Given this list of marker genes PRAMEF11 (PRAME family member 11), FHIT, UBA6, CAV3 (caveolin 3), RPL5, DERL1, STYX, WDR26, USP17L6P, FEM1C (NCBI Gene Id 84463), TRIB1, SHARPIN, RNF6, SIRT2, COP1, PTK2, SUMO1, RNF133, PSMD4, CSNK1D (casein kinase 1 delta), PCNP, HSPA1B, RBBP6, RNF5, CAMLG, KLHL23, RNF126 (NCBI Gene Id 55658), SMURF1, ZER1, SPSB1, USP33, FBXL2, MIB1 (MIB E3 ubiquitin protein ligase 1), SIAH3, LTN1, DCST1, FBXL5, TRIM2, HUWE1, TRIM72, PSMD9, ARK2N, CHMP4C, SPSB3 (NCBI Gene Id 90864), LIAT1, RBCK1, RNF20, ANAPC5, UBXN2A, TP53INP2 (NCBI Gene Id 58476), FBXL13, MDM2, FBXO48, RNF19B, RNF25, FBXL4, KLHL5, HERC5, TENT4A, PANO1, PABPN1L, PSMC6, FBXO39, PRAMEF6, TRIM31, UBQLN2, MAEA, SMAD7, PSMB10, KLHDC1, ADRM1, UBE2G1, AMBRA1, TMEM168, UBXN1, FBXL15, PRAMEF10, KLHL29, GID8, UBE3C, PRAMEF14, AURKA, APC, RNF186, LONP1, RNF7, PRAMEF33, DCAF11, KCTD10, RNF166, AGTPBP1, ASB2, TRIM32, KLF1, USP5, ECRG4, HERC6, HSPA1A, UBE2R2, MAPK9, STAM, ARRB2, SH3RF1, FAF1, KLHDC3, TRPC4AP (NCBI Gene Id 26133), VPS28, DVL1, UBE3B (ubiquitin protein ligase E3B), KLHL25, RNF19A, UBE2Z, SQSTM1, UBR4, SNF8 (SNF8 subunit of ESCRT-II), ASB1, FBXL19, UFD1, CDK5RAP3, CDC20B, FOXF2, CHMP1A, MKRN2, FBXW8, KLHL8, DCAF1, SKP1, GET4, UBE2D4, USP9X (ubiquitin specific peptidase 9 X-linked), PSMB7, ANAPC2, FBXO11, TNFAIP3, KLHL3, TRIP4, SPSB2, PJA2, KCTD2, HECTD1, UBE2H (NCBI Gene Id 7328), TRIM39, DNAJB2, RNF4, UBE2D2, PCYOX1, HERC3, CHMP2B, FBXL7, ATXN3L, TGFB1I1, FBXL3, KBTBD3, UBQLN1, SMARCC1, PSMD2, CUL4A, CHFR, PIAS1, PSMA5, NCCRP1, PRAMEF5, RNF144A, SIAH1, KLHL12, RNF8, GSK3A, VPS37A, RNF34 (NCBI Gene Id 96268), CHMP1B, PSMC3, IFI27, GIPC1, PSMC2, CLU, PSMC5, RNF167, PRAMEF27, UBXN2B, NHLRC1, KLHL30, HAMP, ARRB1, ANAPC15, CHMP7, WWP1, DDRGK1, COPS3, TRIM45, NHLRC3, AKT1, RNF150, PEX12, MTM1, PSMD13, PAQR3, TBL1X, PSMB4, UBE2N, USP38, CHMP4A, PRAMEF13, STUB1, PABIR1, AREL1, UBC, CUL4B, SPSB4, ITCH, CDC20, FAU, IPP, UCHL5, CHMP5, RNF130, HECW1, ZSWIM8 (NCBI Gene Id 23053), UBA7, PSMD11, FBXO38, RNF185, CUL5, BTRC, TRIM58, UBE2L3, PSMD1, KLHL20, CDC23, UBD, DDA1, STAM2, PRKN, RNF144B, UFL1, USP44, USP28, RNF115, RHOBTB3, UBE3D, CDK2, CSNK2A1, PRAMEF25, RNF170, CNOT4, RAD23A, COMMD1, PRAMEF26, UBE2E1, ARMC8, PSMD12, PSMB2, SH3RF2, RMND5A, LRRK2, PEX10, UBA1, KBTBD8, XPO1, SIAH2, KLHL24, NTAN1, PRAMEF4, PELI1, WWTR1, KLHL11, RNF43, CDKN2A, SIRT6, FBXO2, MYLIP, ZFAND2B, PLK1, FBXW4, KCTD13, UBE2S, AXIN2, CSNK2A2, PSMB3, CHMP6, SOCS5, SEM1, NAGLU (N-acetyl-alpha-glucosaminidase), SPOP, PSMB6 (NCBI Gene Id 95505), PARK7, SOCS7, TRIM9, CCDC22, FBXO3, WNT10B, NKD2, UBE3A, SHH, VPS37D, AXIN1, PCYOX1L, CUL3 (NCBI Gene Id 8452), ARMC5, CDC16, TRIP12, PPP2CB, RNF128, TRIM38, ANAPC10, KLHL1, DTL, PRAMEF2, APC2, KLHL28, MAP1A, UBQLN3, SENP1, KLHL40, RPS7, FBXW11, LATS1, FBXO45, HACE1, FBXO4, RNF125, UBQLNL, DIS3L2, APPBP2, NEDD4, ASB11 (NCBI Gene Id 140456), ERCC8, KLHL7 (kelch like family member 7), DESI1, PRAMEF20, USP17L24, VHL, CBLC, GSK3B, UBAP1L, TOLLIP, WDR81, PRAMEF1, BAG5, RNF145, FBXO21 (F-box protein 21), GBA1 (glucosylceramidase beta 1), PSMA2, PDCL3, VPS4A, IL33, USP14, RNF217, DDIT3, FBXL17 (F-box and leucine rich repeat protein 17), PBK, MARCHF6, ASB9, ANKIB1, KLHL21, PSMF1, TRAF4, NPLOC4, RPL23, USP7, VPS25, CSNK1A1, HERPUD1, RNF149, PSMD8, TF, KEAP1, RNF13, KAT5, DTX4, TRIM25, EDEM1, ZMPSTE24, RNF10, GCLC, CCAR2, PRAMEF9, RC3H1, SIRT1, PHF20L1, FBXO6, VPS4B, KCTD21, KBTBD2, OGT, AMFR, OTUD7B, PRAME, CHMP4BP1, UBB, AGBL4, ATXN3, UBXN11, KLHL4, KLHL17, RPL11, TSG101, TRIM3, PSMD6, FZR1, KIF14, PSMA8, RNF215, PPP2R5C, MTA1, NUB1, CUL9, ISG15, AGAP3, DISC1, NFE2L2, BFAR, FBXL16, ATE1, RC3H2, RBX1 (NCBI Gene Id 9978), UBE2D3, CCNF, HECTD3, FBXL14, PSMA4, SMURF2, HERC2, ARAF, PRAMEF22, PSMC1, CDC27, UBE2W, NEDD4L, DCAF12, CRBN, EPG5, CBL, PRAMEF12, PSMD14 (proteasome 26S subunit, non-ATPase 14), UBE2J2, ANAPC1, RAD23B, PSMD7, RNF122, GID4, ARHGAP5-AS1, PYHIN1, PSMD10, ZYG11B, UBR5, FBXW7, UBR1, UBR3, KLHL35, PSMB11, PRMT6, DTX3L, NEMF, UBE2K, CACUL1, BIRC2, VPS36, TTC3, SKP2, VPS37B, UBE4A, LAPTM5, ANAPC11, ASCC2, PLK3, ARIH2, N4BP1 (NEDD4 binding protein 1), DCAF13, CHMP2A, GABARAP, FBXO10, TTC36, ZNRF2, FBXO7, FBXO22, RNF139, FBXL20, AKIRIN2, HSPBP1, ANAPC16, SH3RF3, KLHL22, RMND5B, IVNS1ABP, CCIN, HFE, ZFAND2A, RYBP, PSMB1, RNF148, RPS27A, FBXO9, CUL2, LRRC75A, TLK2, UBR2, PRICKLE1, UCHL3, PSMD3, UBXN7, KBTBD6, FBXL22, KLHDC10, AFG2B, KLHL18, RACK1, TRIM67, CTNNB1, FBXO31, PRAMEF8, TRIM28, NDFIP1, PTPN23, FBXW5, RNF114, QRICH2, RCHY1, SYVN1, SOCS4, USP26 (NCBI Gene Id 83844), TBX21, KBTBD12, SUMO2, CSNK2B, OTUD7A, CHMP4B, FBXO27, PRAMEF19, KLHL42, ZNF418, MTOR, WAC, TRIB3, BBS7, KLHL10, NDFIP2, UBL7, FEM1B, CEBPA, MAGEF1, PTEN, BAG2, TRIM71, UBE4B, EPM2A, PSMA3, UBE2G2, FBXL6, CSNK1E, PSMC4, RFPL1, FBXL18, TRIB2, RNF26, RNF40, MVB12B, KLHL6, UBAP1, UBE2L5, ZNRF4, DDB1, RNF213, RNF180, NEDD8, RNF14, VPS37C, UCHL1, TAF9 (TATA-box binding protein associated factor 9), RNF146, HECW2, PML, PSMB8, UBR7, TUT7, TRIM26, HGS, TAF1, CCAR1, GNA12, KLHL38, ASCC3, TUT4, VCP, OS9, ZNF598, HDAC6, SOCS2, SGTA, CDC34, KLHL15, TRAF7, CDC26, EGF, KCTD5, BAP1, RNF123, DAB2, TRIM13, PCBP2, KCTD17, PRAMEF7, KCMF1, CUL7, PTK2B, UBQLN4, FAF2, PRAMEF15, HIPK2, ANKRD9, CHMP3, RLIM, UBE2A (NCBI Gene Id 7319), SH3BGRL, TNFAIP1, FBXO17, PPP1R11, RNF111, UBE2L6, ANAPC4, PSMA1, CUL1, ELOB, PRAMEF18, PINK1, BMAL1, ZRANB1, HSP90AB1, CLOCK, UHRF1 (ubiquitin like with PHD and ring finger domains 1), AMN1, WWP2, BAG6, FBXL12, KLHL41, ELOC, UBE2C, FBXO8, UBE2I, DMAC2, UBE2U, UBE2B, PSMA6, PLAA, PSMB5, PRAMEF17, ZNRF1, PSMB9, MVB12A, HERC4, FEM1A, WDR77, WNT1, ANAPC13, UBE2D1 (NCBI Gene Id 9335), RNF168, GLMN, RNF187, ARIH1, KCTD6, SPOPL, KBTBD7, CBFA2T3, ZNRF3, EIF3H (eukaryotic translation initiation factor 3 subunit H), TBL1XR1, BCAP31, PSMA7, LNX1, NSFL1C, RPGR, TOM1L1, TOPORS, TMEM129, UBA52, FBXO44, RFFL, IKBKG, NOP53, WDR91, PSEN1, UBL4A, ARRDC1, ANAPC7, XBP1, L3MBTL3, KLHL2, TENT4B, KLHDC2, SUFU, RNF11, GAN, DET1, FBXO46, RNF216, here is a description of the gene set: The chemical reactions and pathways resulting in the breakdown of a macromolecule, initiated by covalent modification of the target molecule. studied in species Homo sapiens Human Gene Set: GOBP_MODIFICATION_DEPENDENT_MACROMOLECULE_CATABOLIC_PROCESS